Given this list of marker genes B3galt1, Galc, Gla, B4galt3, Psap, Ugcg (NCBI Gene Id 97164), Gal3st1, Fa2h (fatty acid 2-hydroxylase), Gba2, Ugt8a, Prkcd, B3galt2, St6galnac3, Lct, St6galnac6, Gba1, here is a description of the gene set: The chemical reactions and pathways involving glycosylceramides, any compound formed by the replacement of the glycosidic hydroxyl group of a cyclic form of a monosaccharide (or derivative) by a ceramide group. Mouse Gene Set: GOBP_GLYCOSYLCERAMIDE_METABOLIC_PROCESS species: Mus musculus